Given this list of marker genes PDE4D, SLC35B2, CANT1, SETD2, NANS, PTH1R (NCBI Gene Id 5745), B3GALT6, SLC10A7, SLC35D1 (solute carrier family 35 member D1), XYLT1, here is a description of the gene set: Ossification of carpal bones at an abnormally early age. studied in species Homo sapiens Human Gene Set: HP_ADVANCED_OSSIFICATION_OF_CARPAL_BONES Advanced ossification of carpal bones